Given this list of marker genes PES1, RPS6, UPF1, TXNL4A (thioredoxin like 4A), GRSF1, CTU2, PWP2, SKIC8, LAGE3, PRPF40A, XRN2, FYTTD1, SMG9, PSMB5, RBM39, DCP2, CCDC12, SF1, MT-RNR1, CNOT3, CNOT2, RBMX2, RPS27L, WDR12, C1D, RBM10, XPOT, BUD23 (NCBI Gene Id 84118), HSPB1, WTAP, NAT10, SAP18, TCERG1, DDX39A, RCL1, PSMD12, RPS24, CNOT6L, RPS10, RPL13A, PPP2CA, RPL23 (ribosomal protein L23), SLIRP, PRPF38A, HBS1L, CDC5L, WDR4, RIOK3, NCBP2, GEMIN8, METTL1, CPSF1, CTU1, APOBEC2, ZRSR2, ACIN1, LUC7L3, RPLP1, CTNNBL1, APOBEC3H, NOP56, RPL10L, UBA52, NUP98, RTCB, EXOSC5, THG1L, PCF11, RBM5, ETF1, SEC13, PRPF3, FIP1L1, PRMT5, EXOSC7, NXF1, TRMT10C, TRMU, EPRS1, MT-RNR2, TNKS1BP1, C9orf78, PSMA6, FASTKD5, ALKBH8, TSEN2, GEMIN5, SMU1, SNRPF, PPIG, RPL37A, PRKCD, U2SURP, REXO2, STEEP1, UBC, ZCCHC7, RPL15, POLR2B, FTSJ3, HTATSF1, ZFC3H1, PSMC6, HNRNPL, PAPOLG, RPS26, AAAS, PSMB7, APOBEC1, ZMAT2, BCAS2, PPIL3, POLR2E, RPL26, GLE1, AKT1, GTF2H5, SNRNP25, RPL10A, RPS15A, RPS19, SRSF7, RNMT, RPL27A, LSM2, NCL, CPSF6, ZNF830, ANP32A, RPL12, XPO1, CNOT10, A1CF, PATL1, HNRNPK, NXF2, RRP9, SRSF6, RPL34, TUT7, MTERF4, NUP85, ADAR, HNRNPC, SUPV3L1, SNRNP27, PSMD3, MFAP1, NUP160, RPL8, MAPK11, SNRPG, SART1, NUP42, PSMD8, IK, DIS3, SMG5, BYSL, HEATR1, RPS3A, RPL37, RPL36, THOC1, CWC25, RPL27 (NCBI Gene Id 6155), SF3A1, DDX42, GTF2H2, PNO1, CDK7, EDC4, RBM28, EXOSC6, RPL13, DDX1, DCPS, EIF4E, TRMT12, FCF1, YTHDC1, NUP155, TRMT13, NSRP1, TYW3, SUPT5H, PHF5A, SRSF3, MTO1, SF3B2, SNRPB2, RBM27, NT5C3B, RPS5, RPS27A, THOC7, RPPH1, RPL22L1, CNOT8, PSMB3 (proteasome 20S subunit beta 3), TRMT44, SF3B5, PSMA1, CPSF2, SRRM1, NCBP1, DDX46, SNRPA, SNW1 (NCBI Gene Id 22938), YTHDC2, DDX5, RPL3, LSM11, LSM4, PCBP2, FAU, POP5, ZMAT5, THOC2, GSPT1, CNOT7, TENT4A, CRNKL1, PDCD7, SMG1, DIMT1, SMN1, TSR3, RPS23, WBP4, ISY1, WDR82, DUS2, OSGEP, NUP107, PRPF19, LSM7, LSM1, SNRNP200, PNN, PSMA7, SEH1L, SNU13, RANBP2, RPS12, HNRNPA1, APOBEC4, DDX21, EBNA1BP2, POLR2K, SRSF12, RPL30, TRIT1, SRSF4, TUT4, TFB1M, UPF3B, CPSF7 (NCBI Gene Id 79869), PPIL1 (peptidylprolyl isomerase like 1), EIF4G1, CWC27, PPIL2, RPS18, TEX10, CDC40, RPS28, RPSA, TBL3, PCBP1, TYW5, NUP205, RPP40, SMG7, RPS2, NOL9, RPS27, GON7, TSEN34 (NCBI Gene Id 79042), SENP3, ERCC3, PLRG1, RPL32, IGF2BP1, PHAX, NKAP, POM121C, EXOSC3, NOB1, PRPF8, RPL39L, HNRNPH2, RRP36, CSTF2T, RPS21, HSPA1A, TRMT6, UTP14A, NSUN2, PDCD11, SUGP1, MAPKAPK2, SLU7, SNUPN, RPL17, PAIP1, CNOT9, HSPA8, HNRNPD, PAN2, LCMT2, RPS8, HNRNPA2B1, SNRPD2, GTF2H3, SNRPA1, AQR, ERCC2, EXOSC1, TRMT112 (NCBI Gene Id 51504), PNRC2, NUP50, BMS1, MAGOH, PAN3, POLR2I, SNRNP70, RIOK2, TP53RK, FAM98B, RPP38, PSMA5, RPL6, SNRNP40, TRMT10A, FASTKD2, XRN1, ZCCHC8, UTP4, SRSF5, SNIP1, SNRPC, UTP15, SF3B4, CWC15, PRPF18, POLR2L, SKIC3, NDC1, ADARB1, RPL23A, PSMA4, APOBEC3B, SRSF1, IGF2BP3, PSMD7, WDR77, RPL10, EIF4A3, IMP4, SF3B1, NOP10, SNRNP48, DDX20, GTF2H1, EXOSC2, PRKCA, DNAJC8, NUP210, PABPC1, PPIE, EIF4A2, CHTOP, METTL14, USP39, CLNS1A, DCP1B, GEMIN2, LSM10, RPLP0, PSMC1 (NCBI Gene Id 5700), CCNH, ADRM1, RPL7A, SLBP, TRMT1, HNRNPA3, DDX41, POLDIP3, RPL3L, SF3B3 (NCBI Gene Id 9661), XAB2, DCP1A, BOP1 (BOP1 ribosomal biogenesis factor), PRP4K, HNRNPH1, GTF2H4 (general transcription factor IIH subunit 4), PPP2R1A, GEMIN7, TGS1, TFIP11, EIF4B, RPS20, RBM22, LSM8, SRRT, UTP25, TRMT5, RPL36AL, TSEN54, HSD17B10, NUP153, YWHAB, RRP7A, TYW1, TSR1, WDR70 (NCBI Gene Id 55100), PRCC, RPL9, EXOSC4, TRMT61B, RPS25, RTRAF (NCBI Gene Id 51637), RPL35, CHERP, SRSF9, RNPC3, BUD31, RPS9 (NCBI Gene Id 6203), PPP2R2A, SKIC2, TPRKB, RPL19 (NCBI Gene Id 6143), NUP43, PABPN1, DDX47, PSMD14, PELP1, HNRNPF, RPL14, TPR, RPL24, PSMC3, SNRPN, NIP7, NOP2, GEMIN6, GSPT2, RPL38, WBP11, SNRPB, RNGTT, PRPF4, NHP2, RPL26L1, RBM8A, DXO, TENT4B, RPS4Y2, DKC1, RPL22, RAE1, UTP11, MNAT1, RPL11, LAS1L, TRMT61A (tRNA methyltransferase 61A), HNRNPR, RPL35A, LSM3, ZC3H3, TNPO1, RNPS1, FUS, ADAT2, GCFC2, NUP88, PSMC5, NUP62, THUMPD1, POP7, CWF19L2, TRDMT1, PSMB6, RPLP2, MRM2, RPS17, RPS14, GPATCH1, SMN2, THADA, RPL28, NUP188, NOP58, FBL, RPS13, POLR2C, SET, ZNF473, TBRG4, CSTF2 (NCBI Gene Id 1478), POLR2D, SARNP, UPF2, SRSF10, PSMB1, QTRT1, NSUN6, LUZP4 (NCBI Gene Id 51213), PQBP1, NSUN4, PNPT1, RPS15, PSMD13, RBM7, DDX39B, PSMA2, PTBP1, SF3A3, NOC4L, DHX15, MRM3, QTRT2, RPL39, IGF2BP2, DHX38 (NCBI Gene Id 9785), U2AF2, CACTIN, RAN, GPKOW, UTP3, RNF113A, SYF2 (NCBI Gene Id 25949), RPS4Y1, PSMD6, DHX35, U2AF1L4, EMG1, POP4, CPSF3, RPL41, FAM32A, NUP133, CSNK1D, ZC3H11A, TRMT11, IMP3, GTF2F1 (NCBI Gene Id 2962, general transcription factor IIF subunit 1), C2orf49, RBM25, DDX6, GNL3, LSM6, ZCRB1, CNOT11, PRPF6, SEM1, DHX16, RBM42, ZFP36L1, HNRNPM, NUP58, UBL5, UTP14C, WDR43, RPS16, CNOT1, SMG8, NUP37, SNRPE, SRRM2, NUDT21, NXF2B, PRKRIP1, EFTUD2, SRSF2, NOL11, FAM50A, RPL31, PSMC4, EXOSC8, MPHOSPH10, UTP6, RPP25, RPL4, METTL3, CSTF3, FTSJ1, LTV1, UTP20, CNOT4, SRSF11, CASC3, ZBTB8OS, UBB, WDR3, GEMIN4, RPS7, PSMC2, DHX8, MRM1, CDKAL1, THOC6, CCAR1, ADAT1, WDR46, PPWD1 (NCBI Gene Id 23398), WDR75, THOC5, RPS3, PUS1, NOL12, PUS7, MTREX, APOBEC3A, SMG6, URM1, FASTK (NCBI Gene Id 80166), DHX9, POLR2H, RIOK1, YJU2, DCAF13, POM121, SDE2, GTPBP3, RPL29, MAPK14, PUS3, POLR2A, CNOT6, PUF60, NUP54, DDX23, SNRNP35, EXOSC10, NUP35, ELAC2, RRP1, DDX52, NOP14, NUP93, PSMD11, MPHOSPH6, RPP30, CWC22, ELAVL1, RPS4X, KRR1, PPP1R8, RBM26, RPL18, GAR1, NUP214, DDX49, ALYREF, NXT1, PPIH, PRORP, LRPPRC, LSM5, ISG20L2, CSTF1, ERI1, PSMB2, RPP14, EXOSC9, EDC3, UTP18, LENG1, RPL21 (NCBI Gene Id 6144), SNRPD3, CPSF4, POP1, UPF3A, ZC3H4, THOC3, NOL6, WDR18, DHX37, RBMX, PSMA3, RPS29, SYMPK, RPS11, POLR2G, TRMT9B, PRPF31, PSMD1, WDR33, PPIL4, PSMB4, RPL18A, SF3B6, U2AF1 (NCBI Gene Id 7309), YBX1, GTF2F2, YWHAZ, PAPOLA, APOBEC3C, RPL5, TRNT1, TRA2B, PARN, ADAT3, SRSF8 (NCBI Gene Id 115898), SNRPD1, ZC3H18, POLR2F, MAGOHB, PSMD2, WDR36, KHSRP, ZFP36, BUD13, POLR2J, RBM17, EIF4A1, CLP1, TNFSF13, RPL36A, CSNK1E, SMNDC1, HNRNPU, RPL7, TSEN15, SF3A2, RPP21, here is a description of the gene set: studied in species Homo sapiens Metabolism of RNA Human Gene Set: REACTOME_METABOLISM_OF_RNA